Given this list of marker genes DOCK1, PDE3B, EIF2B5, RASGRP3, EIF2B1, KNDC1, CCZ1, MON1B, LAMTOR3, RAP1A, EIF2B2, ELMO1, SLC38A9, MON1A, WDR41, RGP1, LAMTOR1, SMCR8, LAMTOR4, RMC1, EIF2B4, CCZ1B, LAMTOR2, EIF2B3, C9orf72 (NCBI Gene Id 73205), RIC1, LAMTOR5, here is a description of the gene set: Human Gene Set: GOCC_GUANYL_NUCLEOTIDE_EXCHANGE_FACTOR_COMPLEX species: Homo sapiens A protein complex that stimulates the exchange of guanyl nucleotides associated with a GTPase.